Given this list of marker genes Gpsm2, Ilk, Plk1, Epb41l2, Epb41, Misp, Ezr, Nubp1, Numa1, Ppp1r9b, Gnai1 (G protein subunit alpha i1), Sapcd2, Mex3b, here is a description of the gene set: A process in which a protein is transported to, or maintained in, the cell cortex. Mouse Gene Set: GOBP_PROTEIN_LOCALIZATION_TO_CELL_CORTEX studied in species Mus musculus